Given this list of marker genes DCTN3, NFU1, SLPI, TNRC6B, NEK3, SP3 (NCBI Gene Id 6670), EYA2, CSF2, P4HTM, ACVRL1, FAM13B, DERL1, CASP4, SLC27A1, KCNMB4, STAG1, MKRN1, RIT1, DNAJB4, LAMTOR4, FBXO17, FAM120A, ABI1, HILPDA, LPAR6, DCAF15, TENT5A, LPIN2, PRELID1, MOSPD2, AIP, ANKRD12, SIPA1L1, PHF6, RPL22L1, NAE1, ZNF704, SENP6, PLCH1, LAMC1, TDRD3, LSP1, KNL1, RPL38, SH3BGRL, MACIR (NCBI Gene Id 90355), HEXA, HRC, XRN2, CEP135, IGFBP6, CLK4, IL21R, FOXO3, GSR, TXNDC9, ITK, ATRX, DNAJB13, EPB41, SNX9, GALNS, WASHC4, UFD1, STAG3, PPM1H, NUDT7, CACNB4, TXNDC16, NDUFA13, RAB9A, SNAPC5, C12orf57, RAB5A, CTSF, CAT, ENTPD5, RAD50, FAM133B, OLFM1 (olfactomedin 1), TAFA3, KLK8, DTNBP1 (dystrobrevin binding protein 1), DAAM1, TMEM87B (transmembrane protein 87B), TRIM5, CTDSPL2 (NCBI Gene Id 51496), SPTLC1, TTC14, PIBF1, ZNF354C, ENC1, OTOS, MED20, FGD5, TRAF3IP2, TAPBP, REEP1, VPS4B, RTL8B, TRAPPC6B, SARAF, MPLKIP, YOD1, KIDINS220, EMP3, LTB, LRRC75B, FEZ2, MYCBP2, FAHD2A, SORBS3, RPS6KB1, SMG1, MAPK14, CACNA1B, SART1, GMPPA, RTF2, KIF21B, ROCK2, CLIC1, MSN, SLC41A3, ARID4A, POLD4, USP15, FHIP2B, ZNF217, TMCO1, NEMF, TNFSF4, DYNLT3, DNAJA1, ARIH2, PPIL2, ACVR2A, CASP8AP2, SGO2, PKP2, IQSEC1, TMBIM4, CUL1, TMEM18, OAS2, HRH2, SPATA1 (NCBI Gene Id 64173), PFKP, SPRY2, RHOBTB2 (Rho related BTB domain containing 2), RINL, ZC3H7A, LEPROT, ACYP1, SRP19, IGFLR1, RBX1, LRIF1, TF, TNP2, IRF7, ITGB2, CAMK1D, RBM48, LBR, KIF3A, KCNK5, KXD1, BST2, DUSP5, ATRAID, TGFB3 (NCBI Gene Id 7043), PTPRCAP, CRBN, YWHAQ, PURA, STYX, C6orf118, RPLP0, FOXF1, NETO2, SECISBP2L, ZIC5, PHLDA3, RPL37A, LGALS8, RB1, METTL23, FBXO8, CNTLN, FANCF, DYNLT5, ODF2L, TXK, TIA1, SDF4, KATNA1, ZFAND2A, ERI2, DLK1, here is a description of the gene set: from publication Wei G, Wei L, Zhu J, Zang C, Hu-Li J, Yao Z, Cui K, Kanno Y, Roh TY, Watford WT, Schones DE, Peng W, Sun HW, Paul WE, O'Shea JJ, Zhao K (PMID 19144320) Human Gene Set: GSE14308_TH1_VS_INDUCED_TREG_UP studied in species Homo sapiens Multipotential naïve CD4+ T cells differentiate into distinct lineages including T helper 1 (Th1), Th2, Th17, and inducible T regulatory (iTreg) cells. The remarkable diversity of CD4+ T cells begs the question whether the observed changes reflect terminal differentiation with heritable epigenetic modifications or plasticity in T cell responses. We generated genome-wide histone H3 lysine 4 (H3K4) and lysine 27 (H3K27) trimethylation maps in naïve, Th1, Th2, Th17, iTreg, and natural (n)Treg cells. We found that although modifications of signature cytokine genes (Ifng, Il4, and Il17) partially conform to the expectation of lineage commitment, critical transcription factors such as Tbx21 exhibit a broad spectrum of epigenetic states, consistent with our demonstration of T-bet and IFN-gamma induction in nTreg cells. Our data suggest an epigenetic mechanism underlying the specificity and plasticity of effector and regulatory T cells and also provide a framework for understanding complexity of CD4+ T helper cell differentiation. Genes up-regulated in comparison of Th1 cells versus induced regulatory T cell (Treg).